Given this list of marker genes NGRN, ZNF512, HERC2, NF2, NAA30, IPO7, OCIAD1, TTL, POGK, TNS2, BMPR2, GSPT1 (NCBI Gene Id 2935), PJA2, MTMR4, BOD1L1, HIPK1, KIDINS220, C2CD5, IQCK, WBP2, ABI2, NLK, SNX15, SAP30L, TBC1D10B, FAM168B, FOXO3, GABBR2, CSRNP2, ASCC1, USP19, ZNF529, SELENOI, NAPG, PIP4K2B, POMT2, MAP4K4 (NCBI Gene Id 9448, mitogen-activated protein kinase kinase kinase kinase 4), FAN1, UBE2N, HECTD1, TMEM30A, CLEC16A, PRRC2B, ZNF565, BRD9, MARF1, PNMA8A, RBM8A, ATP6V1A, PTK2, TMEM183A, EPC2, RELCH, CHTOP, CRNKL1, RTN4, PHF10, CHD9, FBXO30, CCDC88A, KDM3B, JKAMP, DYNC1I2 (NCBI Gene Id 1781), KLHL12, MAP1B, SPAST (spastin), FADS1, BTRC, SLC8A2, GSK3B, GBA2, MAPK8IP1, DFFA, PREPL, DNAJB14, RERE, YWHAG, ELP1 (elongator acetyltransferase complex subunit 1), PPIG, ZFP14, USP33, GOLGA7, PPM1B, TAF9B, FBXO21, UFSP2, SPIRE1, EIF4ENIF1, TSPYL4, PRXL2A, TMEM237, CLASP2, IPO9, ZER1, TP53INP2, TSNAX, NAB1, UBR7, MECP2, SPAG9, TRIM37, WSB2, ATG2B, LANCL1 (LanC like glutathione S-transferase 1), RBPJ, YIPF5, KIF5C, TRIM33, XPO6, GZF1, FBXW11, DDX17, SS18L1, UBE2K, SLC35E2A, ZNF84, FAM219A, DCTN4, TMEM245 (transmembrane protein 245), SESN3, CIZ1, RALGPS1, APPBP2, PHC1, RNF41, LEMD3, RAP2A, KLHL11, ACSL3, IPO5, LARGE1, TAFA5, CAND1, FN3KRP, NUP133, MAP6, SNX27, UBE2E3, TNPO2, ZFAND5, ATP6V1B2, GPRASP2, ATXN7L3, ISCA1, TUBGCP3, NDRG3, CIPC, ZNF710 (NCBI Gene Id 374655), NCAM1, OGFOD1, ANKRD17, RABGEF1, ATP2B2, FAM8A1, ZNF275, SIK3 (NCBI Gene Id 80236), CCDC92, GPR107, CS, TBCK, MTMR3, RAN (NCBI Gene Id 87046), EXOSC6, RMDN3, KLHL42, BCL2L1 (NCBI Gene Id 598), MAPK8IP3, CLCN3, SH2B1, BRPF3, KPNA3, PDXP, VPS52, CALM1, STMN3, AAAS, BLTP1, KIF3B, POGZ, WSB1, PHF2, KIF1B, RALGAPA1, ARPP19, CCDC82, MOAP1, MFSD8, ABHD6, PITPNC1, GORASP1, VPS26B, STAMBP, RABL2B, ADO, PHAX, PHYHIPL, here is a description of the gene set: Neighborhood of RAN RAN, member RAS oncogene family in the GCM expression compendium studied in species Homo sapiens Human Gene Set: GCM_RAN Neighborhood of RAN